The following is a description of a gene set: studied in species Mus musculus Mouse Gene Set: GOBP_LENS_FIBER_CELL_MORPHOGENESIS The process in which the structures of a lens fiber cell are generated and organized. This process occurs while the initially relatively unspecialized cell is acquiring the specialized features of a lens fiber cell. A lens fiber cell is any of the elongated, tightly packed cells that make up the bulk of the mature lens in a camera-type eye., and this is the list of marker genes: Abi2, Epha2, Tbc1d20, Prox1, Cryaa, Crygb, Atf4